The following is a description of a gene set: Esophagitis Human Gene Set: HP_ESOPHAGITIS Inflammation of the esophagus. studied in species Homo sapiens, and this is the list of marker genes: CDKN1B, ELF4, RPL11, ADAMTS2, ZFX, SMAD3, TGFB2, PSPH, DOCK8, GLRB, MYH11, GPHN, PHGDH, TCF4, ADAMTSL2, IARS1, CARMIL2, STAT3, TGFB3, SLC2A10, FERMT1, GRB10, GLRA1, PGM3, TGFBR1, STXBP1, ATAD1, TGFBR2, TRAPPC11, DSG1, STAT6, TGFB1, MEN1, CARD8 (caspase recruitment domain family member 8), SLC6A5, ATP7A, LMX1B, REL